The following is a description of a gene set: Reduced ability of the cornea to respond to stimulation. species: Homo sapiens Human Gene Set: HP_DECREASED_CORNEAL_SENSATION Decreased corneal sensation, and this is the list of marker genes: FGF10, TGFBI, CHST6, FGFR2, FGFR3